The following is a description of a gene set: Phosphatidylinositol-5-phosphate (PI5P) may modulate PI3K/AKT signaling in several ways. PI5P is used as a substrate for production of phosphatidylinositol-4,5-bisphosphate, PI(4,5)P2, which serves as a substrate for activated PI3K, resulting in the production of PIP3. The majority of PI(4,5)P2 in the cell, however, is produced from the phosphatidylinositol-4-phosphate (PI4P) substrate. PIP3 is necessary for the activating phosphorylation of AKT. AKT1 can be deactivated by the protein phosphatase 2A (PP2A) complex that contains a regulatory subunit B56-beta (PPP2R5B) or B56-gamma (PPP2R5C). PI5P inhibits AKT1 dephosphorylation by PP2A through an unknown mechanism. Increased PI5P levels correlate with inhibitory phosphorylation(s) of the PP2A complex. MAPK1 (ERK2) and MAPK3 (ERK1) are involved in inhibitory phosphorylation of PP2A, in a process that involves IER3 (IEX-1). It is uncertain, however, whether PI5P is in any way involved in ERK-mediated phosphorylation of PP2A or if it regulates another PP2A kinase. Reactome Pathway: PI5P, PP2A and IER3 Regulate PI3K/AKT Signaling part of: Negative regulation of the PI3K/AKT network species: Homo sapiens, and this is the list of marker genes: PIK3R1 (NCBI Gene Id 5295), EGF, INS, MYD88, ERBB3, RAC1, FGF9, GAB1, AREG, FGF10, EGFR, STRN, PPP2R5E, FGF7 (NCBI Gene Id 82955), ESR1, PIK3R6, PDGFB, KL, FGFR1, KITLG, FLT3, FGF19, CD19, FGF16, NRG4, AKT1, PIP5K1C, IL1RAP, FGF20, MET, PIK3R5, ERBB2, FGFR4, PIP5K1A, NRG1, CD28, KIT, NTRK2, ERBB4, PPP2R5B, CD86, KLB, IRS1, PIK3R2, PIK3CB, PTPN11, RAC2, PPP2R5A, PPP2R1A, BTC, GAB2, FGF17, PIK3R3, ESR2, PPP2CB, ICOS, IRAK1, FGF3, MAPK3, IRS2, CD80, FGF22 (NCBI Gene Id 27006), IRAK4, HGF, IER3, LCK (NCBI Gene Id 95387), INSR, PIK3AP1, TGFA, PIP5K1B, FYN, TRAF6, FGF5, PPP2R1B, VAV1 (vav guanine nucleotide exchange factor 1), NTF4, PIP4K2A, EREG, PIK3CG, FGFR3, FGF6 (NCBI Gene Id 2251), PIK3CA, NRG2, PDGFRA, FGF23, SRC, PIK3CD, PDGFA, FGF4, PPP2CA, GRB2, FLT3LG, PPP2R5C (protein phosphatase 2 regulatory subunit B'gamma), FGF1, NTRK3, IL1RL1, IL33, BDNF, HBEGF, FGF8, EPGN, MAPK1, PIP4K2C, NRG3, NTF3, TRAT1 (T cell receptor associated transmembrane adaptor 1), RHOG, FGFR2, FGF18, PIP4K2B (phosphatidylinositol-5-phosphate 4-kinase type 2 beta), FGF2, PPP2R5D, FRS2, PDGFRB